The following is a description of a gene set: species: Homo sapiens mouse primary BMDCs were stimulated with tlr ligands and gene expression changes were profiled on Affymetrix arrays Genes up-regulated in comparison of dendritic cells (DC) stimulated with Pam3Csk4 (TLR1/2 agonist) at 16 h versus DC cells stimulated with Gardiquimod (TLR7 agonist) at 16 h. Human Gene Set: GSE17721_PAM3CSK4_VS_GADIQUIMOD_16H_BMDC_UP from publication Amit I, Garber M, Chevrier N, Leite AP, Donner Y, Eisenhaure T, Guttman M, Grenier JK, Li W, Zuk O, Schubert LA, Birditt B, Shay T, Goren A, Zhang X, Smith Z, Deering R, McDonald RC, Cabili M, Bernstein BE, Rinn JL, Meissner A, Root DE, Hacohen N, Regev A (PMID 19729616), and this is the list of marker genes: ZYX, TOR1A, AIM2, NANOS1, ITFG1, USP5, KRT2, CRB1, ARPC5, DYRK1A, TOMM40L (NCBI Gene Id 84134), NR1D1, BPNT2, SBNO1, FIS1, HINT3, CCRL2, NOCT, ALDOC (NCBI Gene Id 230), TINAGL1, RNF11, SLC25A29, TULP2, RIC8A, S100A6, LGALS1, UHMK1, BDKRB2, HINT2, IGFBP1, HMGCS1, RPL27 (ribosomal protein L27), TEAD1, STX6, VCL, OPRD1, MRPL33, FKBPL, NPEPPS, KDM6A, FAM3B, PILRA, PCBD2, CCL17, BAALC, USP53, NOMO1, KLF13, CD247, CHST7, GMFG, MBTPS1, IZUMO1R, ANXA8, OPN4, SH3KBP1, PELI1 (NCBI Gene Id 57334), LRRK2, ARX, PGK2 (NCBI Gene Id 5232), SNRNP70, ICAM1, LAMTOR4, GPR12, CD79A, IFITM10, NSG2, SEZ6L2, UBE3C, SERPINA6, TNF, RP9, RTL8C, MAP3K2, DGAT2, BIRC3, MEFV (MEFV innate immunity regulator, pyrin), NIT1, PTS, MT1E, KLF7, ZFP30, SEPTIN2, FBXO43, RUSF1 (NCBI Gene Id 64755), SYNE1, IL9R, PLA2G4F, UBXN1, ARHGAP31, TMEM234, NFKB2, BHLHE40, SFRP2 (secreted frizzled related protein 2), UBLCP1, SLC26A5, PYY, RPS6KA1, CLEC5A, SRSF11, NKX2-8, NKD2, ATP6V1C2, NSF, OSBPL9, ADRB3, UQCRC2 (ubiquinol-cytochrome c reductase core protein 2), MPC2, STING1, WT1, SNX19, TSPAN33, NBEA, ZMPSTE24, COTL1, EDA, NIPSNAP1, ARHGDIB (Rho GDP dissociation inhibitor beta), IL12A, TRIM13, XPR1, HNRNPR, MED12L, ABL1, PSD3, NDFIP1, USP34, PIP4K2A, LIMCH1, ZNF264, TPT1, SFXN3, ALDH1A2, PRODH, ANKEF1, NDUFC2, EIF3G, SUSD2, PYGL, TSPAN12, C11orf16, PRG3, CKS1B, ATP13A3, CIITA, DGLUCY, HSP90AB1, B3GALNT2 (beta-1,3-N-acetylgalactosaminyltransferase 2), RWDD1, CLCN5, P2RX5, CD70, SLURP1, SWI5, CYP2J2, CCL24, DDX27, SFXN1, FAM241B, UQCRFS1, HMGN3, TTYH1, CACNG8, ESRP1, CDC42EP3, SHMT1, SLC1A2, PSMB3, SAC3D1, PPIB, EI24, PAG1, RPS11, SLC25A17, IGFLR1, ZNF703, COL4A1, CHKA (NCBI Gene Id 1119), CD40LG, DDX50, GABRP, MYL2, ACTN1 (NCBI Gene Id 87), RNF144A, CGREF1, DLL1, MKKS, PHKB, AAMDC, ACSL1, C21orf91, EDNRB, SLC39A1, HOXA3, CRTC3, MMP20, CD14, PCOLCE2, ABCA3, IL16